Given this list of marker genes LTB, DEDD2, NF1, CAV1, PPP1CA, NACC2, G0S2, EIF5A, SEPTIN4, IL20RA, NFATC4, CYLD, BAD (NCBI Gene Id 572), IFNB1, RNF183, PARK7 (Parkinsonism associated deglycase), CRADD, S100A9, TNF, HTRA2, STK4, JAK2, PPP2R1A, RAD9A, TAF6, AGTR2, PTPRC, MIR26B, NGFR, TP53, CTSC, INHBA, BECN1, UBB, MIR27B, ITM2C, BID, BBC3, CTSH, FAS, BCL10, TNFSF14, RBCK1, RPL26, TRAF2, STK3, EI24, MAGED1, INHBB, SERINC3, GSDME, IL19, FADD, CD40LG, FIS1, PEA15, MIR449A, BCAP31, MAL, DDIT3, ADCY10, DAB2IP, TNFSF15, TNFSF12, PLAGL2, S100A8, PRKCD, RET, TP53BP1 (NCBI Gene Id 7158), WNT5A, MIR186, THBS1, CASP2, FASLG, PTPN2, TRAF7, TGFB2, EEF1E1, MSX1, RPS7, BCL2L14, FAF1, BAX, FBH1, PML, TPD52L1, STYXL1, FLCN, HSF1, SIRT1, RIPK3, RIPK1 (NCBI Gene Id 8737), BCLAF1, TRIM39, NOX1, CTNNA1, PAK2, MMP2, ING5, PMAIP1, APAF1, LTBR, TP63, NUPR1, SOD1, PPARG, TNFRSF12A, MIR210, MAPK9, BMPR1B, NCK2, TP73, TLR4, AGT, APP, PYCARD, RPS3, BOK, SKIL, SIAH1, FBXW7, ATF3, SFRP1, WWOX, ZSWIM2, MIR16-1, MYC, ADORA2A, SFPQ, NHERF1, MTCH2 (NCBI Gene Id 23788), SP1, MIR15A, MCL1, PPP2R1B, PIAS4, PRKRA, INCA1, NKX3-1, SRPX, BCL2L11, RACK1, TGFBR1, CLU, LTA, VNN1, TNFSF11, NCK1, GPER1, TLR6, TNFSF10, LCK, PDIA3, HYAL2, here is a description of the gene set: Human Gene Set: GOBP_POSITIVE_REGULATION_OF_APOPTOTIC_SIGNALING_PATHWAY species: Homo sapiens Any process that activates or increases the frequency, rate or extent of apoptotic signaling pathway.